The following is a description of a gene set: Genes positively differentially expressed in cell type: Monocyte upon treatment with cytokine: TRAIL in mouse lymph nodes in vivo. from publication Cui A, Huang T, Li S, Ma A, Pérez JL, Sander C, Keskin DB, Wu CJ, Fraenkel E, Hacohen N (PMID 38057668) species: Mus musculus Cytokines mediate cell-cell communication in the immune system and represent important therapeutic targets. A myriad of studies have highlighted their central role in immune function, yet we lack a global view of the cellular responses of each immune cell type to each cytokine. To address this gap, the authors created the Immune Dictionary, a compendium of single-cell transcriptomic profiles of more than 17 immune cell types in response to each of 86 cytokines (>1,400 cytokine-cell type combinations) in mouse lymph nodes in vivo. A cytokine-centric view of the dictionary revealed that most cytokines induce highly cell-type-specific responses. For example, the inflammatory cytokine interleukin-1β induces distinct gene programmes in almost every cell type. A cell-type-centric view of the dictionary identified more than 66 cytokine-driven cellular polarization states across immune cell types, including previously uncharacterized states such as an interleukin-18-induced polyfunctional natural killer cell state. Mouse Gene Set: CUI_MONOCYTE_TRAIL_RESPONSE_UP, and this is the list of marker genes: Prpsap2, Fbxo8, Pram1, Arl10 (NCBI Gene Id 56795), Dgkd, Mrpl44, Mrm3, Zfp280c, Tmem65